The following is a description of a gene set: Human Gene Set: MIR376A_5P Genes predicted to be targets of miRBase v22 microRNA hsa-miR-376a-5p in miRDB v6.0 with MirTarget v4 prediction scores > 80 (high confidence targets). from publication Chen Y, Wang X (PMID 31504780) studied in species Homo sapiens, and this is the list of marker genes: ATP7B, JUNB, ITK, MELK, CENPU, SLC39A1, SLC17A6, F13B, STAU2, TMTC3, ST3GAL6, CYP39A1, PIP4K2A (NCBI Gene Id 5305), P2RY10, MGST1, ZNF160, GABRR2, SACS, PTHLH, FUT9, MYH9, SEC23B, ERP29, RGS7BP, MUS81, IGFL4, N4BP2L1, SLC35F5, ADAMTS5, CAMSAP2, GPR182, WDR26, KIAA1549, APOF, RBFOX1, CD99, ADAP2, ARHGAP5, RSPRY1, ZC3H12C, EPHA7, PLAG1, VPS13D, FH, GPATCH2L, KIF5C (NCBI Gene Id 7860), MMS19, CA8, PITRM1, KRT222, PRKCA, IL7, EMB, TAFA1, CAVIN2, PIK3C2A, UBAP1 (NCBI Gene Id 51271), CRISPLD1, MDH1, ERLIN2